The following is a description of a gene set: species: Homo sapiens Chaperone Mediated Autophagy Human Gene Set: REACTOME_CHAPERONE_MEDIATED_AUTOPHAGY, and this is the list of marker genes: HSP90AB1, LAMP2, IFT88, HSP90AA1, GFAP, PCNT, PLIN3, CETN1, UBA52, CFTR, EEF1A1, VIM, HBB, ARL13B, HSPA8, HDAC6, UBB, UBC, RPS27A, RNASE1, PARK7, PLIN2